Given this list of marker genes Ufd1, Dhx58, C1qbp, Nploc4, Gpatch3, Nlrx1, Sec14l1 (SEC14-like lipid binding 1), Rnf125, here is a description of the gene set: Mouse Gene Set: GOBP_NEGATIVE_REGULATION_OF_RIG_I_SIGNALING_PATHWAY Any process that stops, prevents, or reduces the frequency, rate or extent of the RIG-I signaling pathway. studied in species Mus musculus